The following is a description of a gene set: Transcription of the HIV genome studied in species Homo sapiens Human Gene Set: REACTOME_TRANSCRIPTION_OF_THE_HIV_GENOME, and this is the list of marker genes: TAF3, NELFE, GTF2E2, TAF6, POLR2F, CCNK, TAF9, TAF13, GTF2H3, POLR2B, ELL, NCBP2 (nuclear cap binding protein subunit 2), CTDP1, TAF12, TAF10, ELOB, GTF2E1, TAF1, POLR2E, POLR2A (RNA polymerase II subunit A), SUPT4H1, TBP (TATA-box binding protein), POLR2G, POLR2H, NELFA, TAF5, POLR2D, TCEA1, GTF2A1, TAF1L, POLR2J, NCBP1, POLR2I, NELFCD, TAF7, TAF15, POLR2K, CCNH, TAF4, GTF2H2, CDK9 (cyclin dependent kinase 9), TAF11, ERCC2, ELOA2, MNAT1, GTF2F1, GTF2F2, GTF2A2, POLR2C, GTF2H5, ELOC, SUPT16H (SPT16 homolog, facilitates chromatin remodeling subunit), TAF4B, GTF2H1, RNGTT, TAF2, NELFB, TAF9B, SSRP1, CCNT1, ELOA, GTF2B, CDK7, CCNT2, TAF7L (NCBI Gene Id 79945), GTF2H4, RNMT, SUPT5H, ERCC3, POLR2L (NCBI Gene Id 5441)